The following is a description of a gene set: species: Homo sapiens The process whose specific outcome is the progression of the glomerular basement membrane over time, from its formation to the mature structure. The glomerular basement membrane is the basal laminal portion of the glomerulus which performs the actual filtration. Human Gene Set: GOBP_GLOMERULAR_BASEMENT_MEMBRANE_DEVELOPMENT, and this is the list of marker genes: NID1, LAMB2, SULF1, COL4A3, NPHS1, SULF2, COL4A4, MYO1E, EXT1, MPV17 (mitochondrial inner membrane protein MPV17), WT1